The following is a description of a gene set: The chemical reactions and pathways resulting in the formation of putrescine, 1,4-diaminobutane; putrescine can be synthesized from arginine or ornithine and is the metabolic precursor of spermidine and spermine. studied in species Homo sapiens Human Gene Set: GOBP_PUTRESCINE_BIOSYNTHETIC_PROCESS, and this is the list of marker genes: ODC1, AZIN1, PAOX, AGMAT, AZIN2